Given this list of marker genes FGF14 (NCBI Gene Id 317685), PCSK5, COL5A1, LPA, OGFOD2, EBI3, ITIH4, SERPINA6, C1QTNF9, CSH1, PRL, SFTPA1, WNT2 (NCBI Gene Id 7472), SDC2, MUC21, IGFBP5, CPAMD8, ELSPBP1, SERPINB6, LGALS12, IL17D, SPAM1, SLIT1, LOX, ADAMTSL4, CLEC1A, EMILIN2, PDGFB, ECM1, LTBP3, PRG4, ADAM23, COCH, ANGPT4, MEGF9, OPRPN, SERPINC1, CXCL11, ADAM21, HTRA3, IL17C, CPN2, VCAN, TIMP1, CCL14, CLEC18B, S100A7A, IFNB1, CCN6, CST7, ANGPTL5, WNT1, LUM, SEMA4C, COL3A1, GDF3, NPNT, TCHH, VEGFC, MEGF11, S100A10 (NCBI Gene Id 6281), TGFBI, MUC17, C1QTNF9B, S100A1, ACAN, FBN3, MMRN2, MEGF8, CCL15, ADAMTS18, CELA2A, SERPINA7, MUC2, WNT7B, NGLY1, MMP1, PAPLN, WFIKKN2, HYAL4, NID1, SDC3, SNED1, FNDC8, CLEC4M, MEP1A, CRLF3, OSM, OGN, THPO, CXCL12, CTSL, CCL26, IL20, CSH2, LTBP4 (latent transforming growth factor beta binding protein 4), WNT2B, EGF, LOXL4, IFNA13, ANGPTL3, ESM1, CLEC4F, ADAMTS19, FBLN2, MST1L, INHBE, ZFP91, INHA, EGLN1, WNT6, SEMA4B, SFRP2 (secreted frizzled related protein 2), LGI2, BMP8A, PLG, IFNA7, SBSPON, EGLN3, MEGF10, LAMB1, PTN, FGB, COL4A2 (collagen type IV alpha 2 chain), SERPINI2, ADAM10, IL36G, SPOCK1, ECM2, LGALS4, CCL20, DMP1, CST4 (NCBI Gene Id 1472), COLQ, PCOLCE, CTSE, IGFBPL1, CDCP2, IGFBP2, EDA, COLEC12, CLEC4E, LGALSL, ANGPTL6, TGM6, SDC4, VWA1, ASTL (NCBI Gene Id 431705), MUC1, CRISPLD1, C1QL3, SERPINB11, FREM1, PAPPA, CSF2, CSHL1, XCL1, MATN1 (NCBI Gene Id 4146), CXCL14, GREM1, LGALS1, EGFLAM, CLEC12B, ADAM15, CTSG, AEBP1, IGF2, CILP2, SERPINB8, IL24, FCN1 (ficolin 1), CSF3 (NCBI Gene Id 170794), IFNA16, CSPG4, FRZB, CSF1, C1QTNF4, MUC16, NTN4, SERPINB3, MFAP5, CELA3B, ELFN1, WFIKKN1, VEGFB, ADIPOQ, FGF1, SERPING1, CCL17, SERPINB5, CLEC2L, COL10A1, NGF, FBN2, DSPP, CBLN4, COL14A1, SRPX, ABI3BP, GH1, VWA3A, PXDNL, S100P, SFTPA2, F13A1, S100A7, MFAP2, ADAM33, IL25, NCAN, LAMB3, SERPINB13, LGALS2, ST14, ADAMTS9, CST5, LGI1, TNFSF13, IL12A, PI3, MUC7, LAMA5, SERPINH1, NDNF, FGFBP3, IL16, BMP6, PLOD3, IL9, SERPINE3, PRELP, VIT, C1QL2, NELL2, LAMC2, MMRN1, ADAMTS7, C1QA, SERPINA4, COL9A1, NRG4, BMP10, ELN, C1QC, SEMA3D, IFNA14, FGG, CXCL3, HPX, WNT8B, IFNE, ADAMTSL3, IL2, SERPINF1, CLEC10A, P3H2, VWC2L, MMP8, FGF11, ADAMTSL5, NYX, SEMA4A, IL1F10, WNT9B, INTS14, TLL2, CELA2B, LAMA2, SERPINE1, IGFBP3, DHH (desert hedgehog signaling molecule), IL6, IMPG2, P4HA3, INS, GDF2, SPOCK3, SMOC2, BGLAP, SCUBE3, OTOL1, LTA, ADAM29, MUC5B, GDF10, LAMB4, EFEMP2, HYAL2, CLEC2D, S100A13, FGF22, CCL3L3, GDF9, MDK, CRIPTO, SERPINA11, GDF7, NTF3, CTSZ, COL25A1, THBS2, MMP10, NELL1, ZPLD1, ADAMTS2, COL28A1, MMP21, PLXNA4, EMILIN3, ZP1, PF4V1, SEMA7A, THSD4, CLC, FGF3, POMZP3, RPTN, LAMC1, BMP2, SEMA4D, CSPG5, SEMA5B, ADAM8, MMP3, CCN4, F7, PRSS3, BSPH1, PPBP, MBL2, PIK3IP1, DCN, LAMA4, FGFBP2, ADAMTS4, NTNG1, PLOD1, WNT4, COL8A1, CST9L, LGALS9, KY, IFNA5, VWDE, CTSV, SEMA4F, S100A2 (S100 calcium binding protein A2), SERPIND1, ITIH6, SLPI, C1QL1, CILP, MMP25, PF4, SRPX2, ELFN2, REG3A, LGALS16, KAZALD1, LRG1, LEP, PLXNB3, RELN (NCBI Gene Id 5649), CCL19, CCL5, CTSC, LAMC3, LIF, SFTPC, TGM7, ADAM32, CHRDL1, FGF13, EGFL7, SERPINA12 (serpin family A member 12), FNDC1, HRNR, MMP20 (NCBI Gene Id 9313), AREG, FGF12, FGL2, A2M, XCL2, SERPINA3 (serpin family A member 3, NCBI Gene Id 95022), FGF9, CLEC19A, SPOCK2, IL13, CST8, TNFSF14, ADAMTS14 (ADAM metallopeptidase with thrombospondin type 1 motif 14), SCUBE2, MMP7, ADAMTS15, INSL6, P4HA2, HABP2 (hyaluronan binding protein 2), F2, SERPINA5, SEMA3A, REG1A, FCN2, FREM2, ZP2, CBLN1, GDF5, COL6A3, INHBC, RSPO2, SULF1, IL1B, CLEC5A, TNR, CST9, IL5 (NCBI Gene Id 3567), MUC19, SPARC, SPARCL1 (SPARC like 1), CSTL1, FGA, FGF17, HPSE2, FST, COLEC10, S100A9, IL1A, CRNN, MMP16, ADAMTS3, MUC4, COL9A3, S100A6, SERPINA2, F12, HMCN1, ITIH3, CTSD, COL15A1, SEMA3B, TNFSF13B, IFNW1, GH2, CTSS, COL22A1, CLEC11A, ZP3, CHRDL2, CST2, TNFSF4, SLIT2, CXCL9, EREG, IFNA17, HYAL3, A2ML1, TIMP4, FSTL3, BTC (betacellulin), CLEC3A (NCBI Gene Id 10143), DPT, POSTN, CCN2, CXCL13, VWA2, TCHHL1, COL7A1, IL12B, OTOG, PLOD2, REG1B, FGF20, OIT3 (oncoprotein induced transcript 3), LTBP1, INS-IGF2, COL9A2, CCL7, HTRA4, MMP19, BMPER, MEPE, IL22, SERPINB9, MUC3A, TGFB3, ADAMTS16, CSTB, CCL11, MFAP1, ARTN, ADAMTSL2, P4HA1, S100B, SEMA6D, PLAU, MMP27, COL6A2, SERPINB7, CD209, S100A8, VWCE, GPC6, EPYC, AGRN, PODN (NCBI Gene Id 127435), SEMA6A, CCL23, MSTN, CTSO, BMP8B, VWA7, FAM20C, COL17A1, FLG, COL1A1, THBS4, ANXA11, COL12A1, FREM3, PRSS12, IL17F, TGM5, CCL2, BMP4, MUC12, BMP15, ADAM20, ISM1, ANXA9, HYAL1, SERPINB12, TNN, IFNA21, TNFAIP6, IFNA10, CHADL, ADAMTS10, COL13A1, MST1, MMP2, COL20A1, PLXNB2, IL17B, C1QTNF1, IL37, PLAT, WNT8A, FGF18, CXCL5 (NCBI Gene Id 6374), GPC3, MATN3, TGM3, TNFSF18, CCL1, ADAM30, HHIP, SEMA5A, EMCN, COL23A1, INSL3, PXDN, LAMB2, FRAS1, CCL13, OVGP1, ADAMDEC1, LGALS9B, MEP1B, CLEC2A, PLXDC2, CHRD, MFGE8, LTB, KITLG, SERPINA9, IGFBP1 (NCBI Gene Id 3484), IL19, FAM20B, FGF8, VWA5B2, CST1, NRG1, TINAGL1 (NCBI Gene Id 64129), ANXA6, COL4A5, PLXDC1, ANXA8, SEMA6B, CRELD2, CBLN3, EGFL6 (EGF like domain multiple 6), PLXNC1, WNT16, COL27A1, ITIH1, P3H1, MUC22, TECTB, CXCL1, ADAM28, ADAMTS5, VWA5A, COL11A2, SERPINF2, CLEC6A, CCN5, ITLN2, FASLG, S100A7L2, TGM4, LOXL2, FGF5, ADAMTS17, FGF4, CRHBP, LGALS8, CLEC3B, MMP9, HPSE, LEFTY1, CTSK, GLDN, SERPINI1, CXCL10, COL4A1, LGALS7, COL1A2 (collagen type I alpha 2 chain), CRIM1, OMD, IFNA8, C1QTNF2, CLCF1, LTBP2, C1QTNF5, CXCL8, PAPPA2, FSTL1, HCFC2, C1QTNF6, INHBB, CCN1, CLEC1B, ANXA10, COL26A1, CFC1, FGF16, CHAD, MUC6, LGALS13, COL5A3, MMP26, CCL21, BCAN, PRSS1, LOXL3, CLEC18A, MFAP3, COL18A1, VWA3B, BRINP3, MGP, CST6, IL34, CRISPLD2, FNDC7, S100A11, HTRA1, IL15, AMELX (amelogenin X-linked), TNFSF11 (TNF superfamily member 11), CTSW, CLEC7A, ADAMTS1, SRGN, IMPG1, COL6A6 (collagen type VI alpha 6 chain), ANGPT1, COL11A1, COL8A2 (collagen type VIII alpha 2 chain), CCL22, NTN5, PGF, P4HTM, NRG3, CCL16, SFTA3, ELANE, RSPO4, ADAM17, SERPINA10, CCL4, IL10, SEMA3C, CCL18, BMP7, MUC5AC, CRELD1, WNT9A, CLEC12A, WNT10A, MFAP4, SEMA3G, LOXL1, MUC13, ANXA7 (annexin A7), COL19A1, NRTN, SEMA3F, ITIH5, CLEC14A, MUC20, COL4A4, EYS, GPC4, VEGFA, PLXNB1, TNXB, BDNF, CBLN2, ADAM11, HAPLN2, PRG2, AMELY, COL24A1, IFNA2, PRG3, ANXA4, BMP1, COL4A6, ASPN, IL7, S100A12, TIMP2, PDGFD, SVEP1, ANXA2, WNT5B, CLEC9A, EPO, MMP14, IL3, MMP12, KNG1, S100A16, SSPOP, VEGFD, FCN3, LGI4, MEGF6, HSPG2, AMBP, PAMR1, HMSD, SFTA2, COL6A5, COLEC11, SFRP4, ADAMTS20, ADAMTS13, IL23A, GDNF, IGFBP6, IL4, IGSF10, HRG, CNTF, PLXNA3 (plexin A3), SDC1, HBEGF, COL16A1, PCSK6, MMP24, TNFSF10, ZP4, SERPINE2, IFNA4, ADAMTS12, C1QTNF8, COL21A1, SERPINB1, TNC, ANXA13, TLL1, S100A3, HCFC1, VWF, CCN3, SFTPD, GPC2, MUCL1, VTN, C1QL4, MXRA5, GPC5, S100A4, THBS1, CTSF, F10, CRLF1, NID2, NTF4, IL36RN, HMCN2, NTN3, ADAMTS6, FGF7, CCL28, ANXA8L1, LAMA3, SPP1, SERPINB4, WNT10B, SEMA3E, MMP13, C1QTNF7, SMOC1, MMP15, ANXA5, SLIT3, IL26 (interleukin 26), HGFAC, CTF1, VWC2, PLXNA2, TGFB1, ITLN1, NRG2, CST11, PCOLCE2, CX3CL1, ADAM2, EMID1, PARM1 (NCBI Gene Id 25849), CSTA, ADAM18, S100A14, EFEMP1, SERPINA1, IL36B, MMP17, CLEC18C, PZP, IGF1, CXCL2, C1QTNF3, TNFSF9, OPTC, COL6A1, IFNK (NCBI Gene Id 95265), ANOS1, IL36A, CLEC2B, LGALS9C, VWA5B1, WNT7A, CCBE1, THBS3, PSPN, IL18, CTSB, TNFSF12, C17orf58, EGLN2, EPGN, SULF2, FGF6, SERPINB2, SFTPB, NTNG2, INTS6L, NTN1, ANGPT2, TECTA (NCBI Gene Id 7007), FGF10, ADAM7, IL17A, WNT11, IFNA6, EGFL8, WNT3, FLG2, EMILIN1, PLXND1, AMBN, GDF6, REG3G, FBN1, HAPLN4, FAM20A, IL11, CFC1B, SPON1, LAMA1, ANGPTL4, CD109, P3H3, TGFB2, CLEC4A, CTSA (cathepsin A), BMP3, LGI3, GPC1, MATN2, COL5A2, WNT5A, CTHRC1, MMP28, FGFBP1, REG4, FLT3LG, PDGFA, FBLN7, TGFA, COL2A1, BRINP2, BGN, RSPO1, HAPLN3, CLEC4C, SPON2, GDF15, ANGPTL1, GDF11, LEFTY2, MUC15, ADAMTS8, PDGFC, TSKU, S100Z, ISM2 (NCBI Gene Id 378772), HAPLN1, F13B, INSL5, IHH, LMAN1L, NODAL, SEMA6C (NCBI Gene Id 81604), FBLN5, TGM1, FGL1, IGFALS, CELA1, COL4A3, LGALS3, LGALS14, TIMP3, S100G, LMAN1, PLXNA1, FBLN1, BMP5, SFRP1, SFRP5, FN1, MMP11, COMP, FGF21, IFNG, MATN4, CCL24, WIF1, CST3, TINAG, GRIFIN, PODNL1, ADAMTSL1, ITIH2, SCUBE1, IL1RN, F9, HGF, ANXA3, CLEC4D, S100A5, FGF2, INHBA, ANXA1, AMH, SERPINB10, CTSH, RSPO3, FGF23, TNFSF15 (TNF superfamily member 15), DMBT1, KERA, ADAM12, CXCL6, TPO, IGFBP7, MASP2, TNF, IGFBP4, FMOD, KCP, CLEC17A, TGM2, ADAM22, ADAM19, USH2A, FGF19, CCL3, TNFSF8 (NCBI Gene Id 944), C1QB, CCL25, SHH, OGFOD1, WNT3A, ADAM9, MASP1, IBSP, CCL8, CCL27 (NCBI Gene Id 10850), ANGPTL7, TSPEAR, GDF1, PRSS2, EDIL3, AGT (angiotensinogen), IFNA1, MMP23B, ANGPTL2, SEMA4G, GAS6, CCL4L2, CELA3A, TMPRSS15, CLEC4G, here is a description of the gene set: Ensemble of genes encoding extracellular matrix and extracellular matrix-associated proteins studied in species Homo sapiens from publication Naba A, Clauser KR, Hoersch S, Liu H, Carr SA, Hynes RO (PMID 22159717) Human Gene Set: NABA_MATRISOME One hallmark of ECM proteins is their domain-based structure. Exploiting this characteristic, we established a list of diagnostic InterPro domains commonly found in ECM proteins. We know that some of the domains used to select positively for ECM proteins are also found in transmembrane receptors and proteins involved in cell adhesion (growth factor receptors, integrins, etc) that do not belong to the ECM. These families of proteins also display a subset of specific domains and transmembrane domains incompatible with definition as “extracellular matrix” proteins. Therefore, a second step comprised a negative selection using another set of domains and a transmembrane domain prediction. Manual curation of the matrisome lists also allowed us to add a very few known ECM proteins that do not contain any known domains. Protein-centric predictions were then converted to gene-centric lists. Finally, knowledge-based annotation of these gene lists allowed us to define subcategories within the core matrisome; namely, ECM glycoproteins, collagens, and proteoglycans. We also defined separate lists of domains commonly found in 1) ECM-affiliated proteins (proteins that share either some architectural similarities with ECM proteins or that are known to be associated with ECM proteins; 2) ECM regulators: ECM-remodeling enzymes, crosslinkers, proteases, regulators etc.; 3) secreted factors, many of which are known to bind to ECM and others that may. As for the core matrisome list, we also defined lists of domains that excluded mis-assigned proteins from these categories. Using similar bioinformatic pipelines as for the core matrisome, we defined three categories of “matrisome-associated” proteins: ECM-affiliated proteins, ECM regulators, and secreted factors.